The following is a description of a gene set: Genes predicted to be targets of miRBase v22 microRNA mmu_miR_6410 in miRDB v6.0 with MirTarget v4 prediction scores > 80 (high confidence targets). studied in species Mus musculus Mouse Gene Set: MIR_6410 from publication Chen Y, Wang X (PMID 31504780), and this is the list of marker genes: Sting1, Crat, Mydgf, Tmem70, Amotl2, Rnf41 (ring finger protein 41), Dlgap4, Rap1b, Kif3b, Vav2 (vav 2 oncogene), Dlc1, Ago3, Pla2g4e, Mecp2, Oxtr, Zxdb, Cers3 (NCBI Gene Id 74802), Snap91, Gal3st2c, Ugcg, Dmrtb1, Btaf1, Nefm, Zfp446, Tcf7, Kcnip1, Reep1, Klhl1, Zfp811, Cdk16 (cyclin dependent kinase 16), Ranbp10, Scml2, Nphp1, Nlrp6, Cmtm4 (CKLF-like MARVEL transmembrane domain containing 4), Map6d1, Abhd13, Pgap4, Nlk, Diaph1, Tspan14, N4bp1, Mbd6, Dhx33, Zfp820, Rmi1, Dmtn, Zfp697, Grik3, B3gnt5, Hspb7, Bcl2l11, Med8, Blzf1, Sesn1, Mapk14, Med13, Rab8a, Rap1a, Abcb9, Dusp8, Fgf11, Tmed8, Rala, Lhpp, Amz1, Lmtk2, Arid5a, Gorab, Skida1, Ube2k, Gad1, Camk2b, G6pdx, Snhg11, Vstm4, Dusp16, Zfp975, Midn, Sphkap, Matr3 (NCBI Gene Id 69967), Polr1e, Rasal1, Dyrk2, Mboat7, Sema4b, Kbtbd13, Tmem161b, Slc25a44, Atp13a2, Cited4, Lrsam1, Zfp68, Fam78b, Mix23, Ipcef1, Als2, Brd8, Tpmt, Nfxl1, Kcnk2, Cdkn1b, Zfp654, Tceanc2 (NCBI Gene Id 72299), Rnf2, Iffo2, Add2, Zswim7, Xpo7, Fsd1l, Chd5, Ago4, Kbtbd6, Rasa1, Stc2, Nrp2, Rnf138, Tmem245, Klk10, Zfp600, Fst, Kcnb1, Pde1a, Insig1, Sdf2, Samd4b, Gfer, Gfpt1, Ptprf, Bhlhe22, 3110082J24Rik, Trp53bp1, Pml, Dagla, Dgkk, Zfp942, Sart1, Kptn, Rps15a, Klf8, H2ax, Polr3d, Trpm1, Gbx2, Hnf1b, Ncl, Bco1, Sptlc2, Plod2, Pkdcc, Nup210, Spon1, Apba1, Stradb, Stx5a, Pigm, Calcr, Klrb1a, Lmbr1l, Zcchc14, Ark2c, Anks1, Mrpl45, Pskh1, Prss44, Lsamp, Gpr151, Ebf2, Specc1, Ccdc25, Mau2, Apob, Top1, Zbtb37, Fam210b, Depdc5, Mboat1, Ndst1, Agps, Magi1, Cyb561d1, Ppp1r16b, Ttc17, Calhm4, Zfp981, Clcn3, Zxdc, Nemp1, Atad2b (ATPase family, AAA domain containing 2B), Igfbp4, Spast, Zfp947, Crebl2, Cdh7, Rap2c, Ntsr1, Mrc2, Il1r1, Laptm4b, Slc16a2, Otud5, Per1, Rubcn, Chmp1b2, Tfcp2l1, 9930012K11Rik, Aldh5a1, Snn, Tmem121b, Ptger4, Taok1, Rex2, B4gat1, Wnt8b, Klhdc9, Sncaip, Rc3h2, Entpd6, Neurod1, Sema4a, Pdgfra, Avl9, Nav2 (neuron navigator 2), Nova2 (NCBI Gene Id 434131), Gal3st3, Plcl2, Agpat1, Dock3 (NCBI Gene Id 638531), Smagp, Rapgef2, Per2, Cnot6, Nadk2, 2510009E07Rik, Luc7l, Zfp980, Tbc1d24, Mxi1, Grip1, Appl2, Rbm3, Mia3, Gm11545, Tor2a, Sstr1, Fyb2, Prdm1, Kctd21, Gnao1, Trim66, Tmem267, Foxred2, Tada2b, C1qtnf1, Vgll3, 2810459M11Rik, Tmem164, Slc25a25